Given this list of marker genes AKR1A1, C1QBP (complement C1q binding protein), CTSS, NDUFA1 (NCBI Gene Id 4694), SOD1, ITPR1, HSPE1, MAP2K1, GAS5, CSF1R, ANP32B, HBA2, NDUFB5, HSD17B4, ACTB, NDUFC1, TBCA, SST, RPL17, ATP5MG, PAFAH1B1, CLK1, PREP, COX7A2, HBB, ATP5F1C, PSMA4, ATP5IF1, CASP6, ATP5MK, PPP1R7, THY1, BTG3 (NCBI Gene Id 10950), PPA1, SNX2, PRDX1, HEXB (hexosaminidase subunit beta), RPS12, TPP1, MAP4, M6PR, CCT6A, B2M, TPD52, PSMD14, PSMA6, ATP5PO, MT1F, SEPTIN4, here is a description of the gene set: Up-regulated in the hypothalamus of aged (22 months) BALB/c mice, compared to young (2 months) controls from publication Jiang CH, Tsien JZ, Schultz PG, Hu Y (PMID 11172053) Human Gene Set: JIANG_AGING_HYPOTHALAMUS_UP A better understanding of the molecular effects of aging in the brain may help to reveal important aspects of organismal aging, as well as processes that lead to age-related brain dysfunction. In this study, we have examined differences in gene expression in the hypothalamus and cortex of young and aged mice by using high-density oligonucleotide arrays. A number of key genes involved in neuronal structure and signaling are differentially expressed in both the aged hypothalamus and cortex, including synaptotagmin I, cAMP-dependent protein kinase C beta, apolipoprotein E, protein phosphatase 2A, and prostaglandin D. Misregulation of these proteins may contribute to age-related memory deficits and neurodegenerative diseases. In addition, many proteases that play essential roles in regulating neuropeptide metabolism, amyloid precursor protein processing, and neuronal apoptosis are up-regulated in the aged brain and likely contribute significantly to brain aging. Finally, a subset of these genes whose expression is affected by aging are oppositely affected by exposure of mice to an enriched environment, suggesting that these genes may play important roles in learning and memory. studied in species Mus musculus